Given this list of marker genes HOXC13, CDSN, FRAS1, FGF10, RNU12, JUP, DSP, EDA, PHGDH, TP63, NECTIN4 (nectin cell adhesion molecule 4), CWC27, RIPK4, ZBTB20, POLR3A, TWIST2, SF3B4, HR, ZMPSTE24, RECQL, RECQL4, POLR1B, KRT85, LMNA (lamin A/C), MBTPS2, ANAPC1, ODC1, SOX18, POLR1D, EDARADD, BRAF, TCOF1, LRP1, KRT74 (NCBI Gene Id 121391), PKP1, GJB2, POLR1C, AR, here is a description of the gene set: Human Gene Set: HP_ABSENT_FACIAL_HAIR Absent facial hair Absence of facial hair. studied in species Homo sapiens